The following is a description of a gene set: species: Homo sapiens The process in which the anatomical structures of the head are generated and organized. The head is the anterior-most division of the body. Human Gene Set: GOBP_HEAD_MORPHOGENESIS, and this is the list of marker genes: SCX, PTPN11, TIPARP, ATP6AP2, TGFB1, STRA6, IHH, CRISPLD2, TBX1, DKK1, CSRNP1, SKI, WNT3, EP300, TGFB2, SSBP3, PLEKHA1, NIPBL, CRISPLD1, CLDN5, FLVCR1, RRAS, MMP2, SGPL1 (sphingosine-1-phosphate lyase 1), RAB3GAP1, NOG, ANKRD11, LEF1, VPS13B, ASPH, MSX1 (NCBI Gene Id 4487), MYH3, BRAF, COL1A1, PRICKLE1, PAX9, TGFB3, DLX5, ARID5B, PDGFRA